Given this list of marker genes ALDH7A1, ACKR1, SERPINA3, PHLDA1, TPM4, GLO1, SRP9, GRIN2B, NPHP1, USP38, RGS16, KRT12, MTIF2, MAPRE1, AKAP1, POU2F1, PSMB6, SCOC, DCAF8, SCG5 (secretogranin V), SORL1, C5orf34, VPS52, PER3, PPDPF, SSBP4, ACAA1, ABHD14A, PDPN, ALAD, TCEA1, CAP1, CCND1, PAM, IGHM, OCIAD1, KCNJ9, KCNH1, C4orf3, CCND2, PTTG1, GRK5, TOX4, PDXDC1, SPOCK1, SSPN, MYO7A, BCAT2, TPBG (trophoblast glycoprotein), RPP14, ALDH9A1, SC5D, THUMPD1, SNHG11, SNHG6, GNB1, NCS1, HJURP, TUBGCP4, CD6, SLC15A2, FAM32A, OCEL1, TULP3, FOLH1, MRPL48, SPG21, PRDX2, CPSF2, RFK, EEF1AKMT1, COP1, CCL21, here is a description of the gene set: Patterns of gene expression in the central nervous system are highly variable and heritable. This genetic variation among normal individuals leads to considerable structural, functional and behavioral differences. We devised a general approach to dissect genetic networks systematically across biological scale, from base pairs to behavior, using a reference population of recombinant inbred strains. We profiled gene expression using Affymetrix oligonucleotide arrays in the BXD recombinant inbred strains, for which we have extensive SNP and haplotype data. We integrated a complementary database comprising 25 years of legacy phenotypic data on these strains. Covariance among gene expression and pharmacological and behavioral traits is often highly significant, corroborates known functional relations and is often generated by common quantitative trait loci. We found that a small number of major-effect quantitative trait loci jointly modulated large sets of transcripts and classical neural phenotypes in patterns specific to each tissue. We developed new analytic and graph theoretical approaches to study shared genetic modulation of networks of traits using gene sets involved in neural synapse function as an example. We built these tools into an open web resource called WebQTL that can be used to test a broad array of hypotheses. from publication Chesler EJ, Lu L, Shou S, Qu Y, Gu J, Wang J, Hsu HC, Mountz JD, Baldwin NE, Langston MA, Threadgill DW, Manly KF, Williams RW (PMID 15711545) Best cis-regulated quantitative trait loci (QTLs) in the mouse genome which modulate transcription in brain tissue. studied in species Mus musculus Human Gene Set: CHESLER_BRAIN_QTL_CIS